Given this list of marker genes OGG1, here is a description of the gene set: species: Homo sapiens OGG1 missense mutants reported in Alzheimer's disease, OGG1 A53T and OGG1 A288V, show decreased binding to 8 oxoguanine substrate. part of: Defective Base Excision Repair Associated with OGG1 Reactome Pathway: Defective OGG1 Substrate Binding